Given this list of marker genes ITGA6, CADM1, CDH19, ZC3H12A, CRB3, NECTIN3, ITGB4, ACTG1, TNRC6C, F11R, CLDN16, CDH8, MOV10, FOXF1, CTNNB1, SDK1 (sidekick cell adhesion molecule 1), NECTIN2, CDH13, NECTIN1, CLDN9, ARHGEF6, ACTN1 (actinin alpha 1), PARD6A, AGO4, CLDN12, ILK, CDH5, PARD6G, CLDN17, CDH10, ANGPTL4, SDK2, SNAI1, CD151 (CD151 molecule (Raph blood group)), CLDN3, SP1, CADM3, CDH15, FERMT2, COL17A1, CTNNA1, LAMC2, LAMA3, CDH11, ADAM19, PVR, TNRC6A, CLDN18, VASP, PRDM8, CLDN7 (NCBI Gene Id 1366), CLDN23, RSU1, PARVB, PRKCI, AGO3, HOXC8, CLDN22, CDH7, CLDN6, ACTB, LIMS2, CDH3, CDH24, CTNND1, CDH6, CDH2, ITGB1, CDH4, PARD3, LAMB3, PARVA, AGO1, FLNC, CLDN11, CLDN8, ILF3, CDH9, FLNA, CDH1, TESK1, CDH18, PATJ, CLDN10, CLDN19, CLDN20, DST, CDH17, CLDN4, CLDN2, CADM2, NECTIN4, KRT5, PXN, TNRC6B, CDH12, AFDN, MIR200C, LIMS1, JUP, CLDN5, PARD6B, CLDN14, AGO2 (NCBI Gene Id 286109), SOX10, FBLIM1 (NCBI Gene Id 54751), ANG, ZEB2, PALS1, KRT14, CLDN15, ADAM33, HEYL, BHLHE22, AMOT, PLEC, CLDN1, here is a description of the gene set: studied in species Homo sapiens Human Gene Set: REACTOME_CELL_JUNCTION_ORGANIZATION Cell junction organization